The following is a description of a gene set: species: Mus musculus Any process that modulates the frequency, rate or extent of phospholipase activity, the hydrolysis of a phospholipid. Mouse Gene Set: GOBP_REGULATION_OF_PHOSPHOLIPASE_ACTIVITY, and this is the list of marker genes: Ccl5, Ang2, Rgs2, Lrp1, Fgfr3, Pla2r1, Snca, Arhgap6, Ang6, Fgfr2, Pla2g5, Ang5, Angptl3, Apoc2 (NCBI Gene Id 11813), Avpr1b, Plaa, Agtr1a, Ccn1, Ang4, Apoc2l, Ang (NCBI Gene Id 11727), Agtr1b